Given this list of marker genes Strn3, Vps11, Lbh, Cnot2, Zfp366, Phb2, Cnot9, Cnot1, Vps18, Isl1, Cnot3, Kank2, Trp63, Cyp7b1, Brca1, Foxh1, here is a description of the gene set: Any process that stops, prevents, or reduces the frequency, rate or extent of the activity of an intracellular estrogen receptor signaling pathway. species: Mus musculus Mouse Gene Set: GOBP_NEGATIVE_REGULATION_OF_INTRACELLULAR_ESTROGEN_RECEPTOR_SIGNALING_PATHWAY